The following is a description of a gene set: Combining with a signal and transmitting the signal from one side of the membrane to the other to initiate a change in cell activity by catalysis of the reaction: ATP + a protein-L-tyrosine = ADP + a protein-L-tyrosine phosphate. Mouse Gene Set: GOMF_TRANSMEMBRANE_RECEPTOR_PROTEIN_TYROSINE_KINASE_ACTIVITY species: Mus musculus, and this is the list of marker genes: Mertk, Igf1r (NCBI Gene Id 77773), Epha10 (Eph receptor A10), Egf, Dgkq, Tie1, Mst1r, Ror2, Alkal2, Kit, Epha8, Ephb6, Flt3, Mup5 (major urinary protein 5), Erbb4, Grem1, Mup4, Fgfr1, Csf1r, Vegfa, Egfr, Fgfr2, Flt4 (NCBI Gene Id 14257), Mup11, Epha1, Epha3, Ephb3, Ltk, Btc, Ephb2, Igf1, Ddr2, Tek, Ephb4, Met (NCBI Gene Id 194383), Flt1, Ephb1, Insrr, Nrg2, Axl (NCBI Gene Id 26362), Pdgfrb, Tgfa, Epha6, Lilrb4b, Alkal1, Insr, Mup1, Ryk, Tyro3, Ntrk2, Ins1, Epgn, Lilrb4a, Erbb2, Efemp1, Mup2, Alk, Ngf, Angpt4, Ntrk3, Ror1 (NCBI Gene Id 72176), Fgfrl1, Fgfr4, Kdr, Hbegf, Epha2, Ins2, Ddr1 (NCBI Gene Id 268950), Epha4, Pdgfra, Ereg, Musk, Fgfr3, Nrp1, Ntrk1, Igf2, Ros1, Ptk7, Nrp2, Areg, Epha5, Mup3, Epha7, Ret